The following is a description of a gene set: Mouse Gene Set: GOMF_MONOCARBOXYLATE_SODIUM_SYMPORTER_ACTIVITY species: Mus musculus Enables the transfer of a solute or solutes from one side of a membrane to the other according to the reaction: monocarboxylate(out) + Na+(out) = monocarboxylate(in) + Na+(in)., and this is the list of marker genes: Slc10a4, Slc5a6, Slc6a1, Slc6a12, Slc10a4-ps, Slc10a5, Slc6a13, Slc6a6, Slc5a8, Slc5a12, Slc6a11, Slc10a2, Slc10a6, Slc10a3, Slc6a8, Slc10a1 (solute carrier family 10 (sodium/bile acid cotransporter family), member 1)